Given this list of marker genes CNTF, ERAP1, IL6, PYCARD, IL6R, IL6ST, ADAM17, here is a description of the gene set: Human Gene Set: GOMF_INTERLEUKIN_6_RECEPTOR_BINDING Binding to an interleukin-6 receptor. studied in species Homo sapiens